The following is a description of a gene set: Metabolism of sphingolipids in ER and Golgi apparatus species: Homo sapiens Human Gene Set: WP_METABOLISM_OF_SPHINGOLIPIDS_IN_ER_AND_GOLGI_APPARATUS, and this is the list of marker genes: GALNT16, CERS3, ST6GALNAC3, SGPP1, CERK, SGPP2, UGT8, GALNT1, B3GALT1, SPHK2, B3GALNT1 (beta-1,3-N-acetylgalactosaminyltransferase 1 (Globoside blood group)), B4GALT1 (NCBI Gene Id 2683), B4GALNT1, B4GALT2, B3GALT2, UGCG, KDSR, SPHK1, SGPL1, SGMS1, SGMS2